The following is a description of a gene set: species: Mus musculus Mouse Gene Set: REACTOME_APEX1_INDEPENDENT_RESOLUTION_OF_AP_SITES_VIA_THE_SINGLE_NUCLEOTIDE_REPLACEMENT_PATHWAY APEX1-Independent Resolution of AP Sites via the Single Nucleotide Replacement Pathway, and this is the list of marker genes: Neil2, Lig3, Xrcc1, Polb, Ogg1 (8-oxoguanine DNA-glycosylase 1), Pnkp, Neil1